The following is a description of a gene set: studied in species Mus musculus Genes up-regulated in liver tissue upon knockout of H2AFY. Mouse Gene Set: CHANGOLKAR_H2AFY_TARGETS_UP macroH2A histone variants have been implicated to function in gene silencing by several studies, including ones showing a preferential association of macroH2A on the inactive X chromosome. To examine macroH2A function in vivo, we knocked out macroH2A1. macroH2A1 knockout mice are viable and fertile. A broad screen of liver gene expression showed no evidence of defects in X inactivation but did identify genes that have increased expression levels in macroH2A1 knockouts. macroH2A1-containing nucleosomes are enriched on the coding and/or upstream regions of these genes, suggesting that their increased expression levels are a direct effect of the absence of macroH2A1. The concentrations of macroH2A1 nucleosomes on these genes are low in the livers of newborn mice, and the macroH2A1 knockout had little effect on the expression levels of these genes in newborn liver. Our results indicate that an increase in liver macroH2A1 during the transition from newborn to young-adult status contributes to a decrease in the expression levels of these genes. These genes cluster in the area of lipid metabolism, and we observed metabolic effects in macroH2A1 knockouts. Our results indicate that the function of macroH2A1 histones is not restricted to gene silencing but also involves fine tuning the expression of specific genes. from publication Changolkar LN, Costanzi C, Leu NA, Chen D, McLaughlin KJ, Pehrson JR (PMID 17242180), and this is the list of marker genes: Sdr39u1, Scd2, Glo1, Slc25a39, Smurf2, Niban2, Cmtm4, Grpel2, Traf4, Ccm2l, Avl9, Tmcc3, Rhou, Tbc1d7, Slc35g1, Car1, Tmem70, Serpina7, Atp11a, Rictor, Abhd1, Enpp3 (ectonucleotide pyrophosphatase/phosphodiesterase 3), Hycc1, Gramd2b, Slc6a8, Dlg3, Ptgfrn, Gnaq, Spsb4, Mapk1ip1, Slc44a1, Mcl1, Tent2, Rora, Cblc, Serpina6, Ivd, Tmem176a, Ibtk, Fnip1, Mysm1, Cct8, Aph1a, Ilvbl, Lpl, Wdr11, Krt23, Smap2, Zc3h12c, Itpk1